Given this list of marker genes CD1A, CD1C, CD1E, CD1D, CD1B, here is a description of the gene set: Binding to a lipid antigen. species: Homo sapiens Human Gene Set: GOMF_LIPID_ANTIGEN_BINDING